The following is a description of a gene set: Mouse Gene Set: CUI_T_CELL_CD4_IL15_RESPONSE_DN Cytokines mediate cell-cell communication in the immune system and represent important therapeutic targets. A myriad of studies have highlighted their central role in immune function, yet we lack a global view of the cellular responses of each immune cell type to each cytokine. To address this gap, the authors created the Immune Dictionary, a compendium of single-cell transcriptomic profiles of more than 17 immune cell types in response to each of 86 cytokines (>1,400 cytokine-cell type combinations) in mouse lymph nodes in vivo. A cytokine-centric view of the dictionary revealed that most cytokines induce highly cell-type-specific responses. For example, the inflammatory cytokine interleukin-1β induces distinct gene programmes in almost every cell type. A cell-type-centric view of the dictionary identified more than 66 cytokine-driven cellular polarization states across immune cell types, including previously uncharacterized states such as an interleukin-18-induced polyfunctional natural killer cell state. Genes negatively differentially expressed in cell type: CD4+ T cell upon treatment with cytokine: IL-15 in mouse lymph nodes in vivo. studied in species Mus musculus from publication Cui A, Huang T, Li S, Ma A, Pérez JL, Sander C, Keskin DB, Wu CJ, Fraenkel E, Hacohen N (PMID 38057668), and this is the list of marker genes: Thy1, Dnajb1, Gramd1a, Crip1, Dusp2, Crlf3, Smc4, Pik3ip1, Btg2, Zfp36l2 (zinc finger protein 36, C3H type-like 2), Mxd4, Actn1, Ctsd, Ets1, Uba52 (NCBI Gene Id 56512), Id3 (NCBI Gene Id 15903), Itpkb (inositol 1,4,5-trisphosphate 3-kinase B), Rgcc, Tsc22d3 (TSC22 domain family, member 3), Fam78a, Klf6, Selenop